Given this list of marker genes MIA2, STMN1, EPHA4, GPSM1, RIPOR1, MET, RIPOR2, here is a description of the gene set: Human Gene Set: GOBP_REGULATION_OF_GUANYL_NUCLEOTIDE_EXCHANGE_FACTOR_ACTIVITY studied in species Homo sapiens Any process that modulates the frequency, rate or extent of guanyl-nucleotide exchange factor activity.